Given this list of marker genes SMAD3, CCN4, COL11A1, RFLNB (NCBI Gene Id 359845), COL27A1, TSKU, WNT2B, MUSTN1, LTBP3, GPLD1, ATF2 (NCBI Gene Id 1386), NPR2, ADAMTS12, NFIB, HMGA2, LNPK, SLC26A2, BPNT2, LOXL2, GALNT3, GDF5, RARB, SULF2, TGFBI, MAF, BMPR1A, WNT9A, SIX2, TRIP11, RUNX2 (NCBI Gene Id 860), ARID5A, ADAMTS7, MATN1, CHSY1, POC1A, SULF1, IFT80, FGF9, COL3A1, PTPN11, GREM1, SNAI2, BMP2, CCN3, ECM1, ZBTB16, SFRP2, TGFBR1 (transforming growth factor beta receptor 1), PTH1R, RUNX3, OSR2, MSX2, MBOAT2, EXT1, ZNF219, NR5A2, GLG1, BMP6, TRPS1 (transcriptional repressor GATA binding 1), CHST11, RUNX1, SMAD7, FOSL2, NPPC, SOX6, HOXA11, MAPK14, SCIN, NKX3-2, FGFR1, SLC39A14, PTH, EFEMP1, OSR1, RB1, PKDCC, CHADL, BMPR2, CTNNB1, ACVRL1, EXT2, POR, PRKG2, RFLNA, AXIN2, CCN2, SCX, CREB3L2, IHH, MEF2C, GDF6, RARG, WNT5B, SOX9, HES5, COL2A1, CYTL1, HIF1A, WNT10B, TGFB1, AMELX, BMP4, FGFR3, WNT7A, EIF2AK3, COMP, PTHLH, SHOX2, TWSG1, MEX3C, SOX5, TGFBR2, SERPINH1, FGF18, SMPD3, BMPR1B, SNX19, GLI3, MDK, here is a description of the gene set: Human Gene Set: GOBP_CHONDROCYTE_DIFFERENTIATION species: Homo sapiens The process in which a chondroblast acquires specialized structural and/or functional features of a chondrocyte. A chondrocyte is a polymorphic cell that forms cartilage.